Given this list of marker genes ATL1, SPG11, TBK1, DCTN1, SOD1, NEFH, SLC33A1, FUS, TARDBP, KPNA3, SQSTM1, PLP1, NIPA1, PRPH, VCP, RTN2, SPG7, CHCHD10, UBAP1, WASHC5, CPT1C, SPAST, here is a description of the gene set: Deterioration of the tissues of the lateral corticospinal tracts. Degeneration of the lateral corticospinal tracts Human Gene Set: HP_DEGENERATION_OF_THE_LATERAL_CORTICOSPINAL_TRACTS studied in species Homo sapiens